The following is a description of a gene set: Reactome Pathway: Aflatoxin activation and detoxification electronically inferred by orthology from the curated human pathway species: Mus musculus part of: Biological oxidations This event has been computationally inferred from an event that has been demonstrated in another species.<p>The inference is based on the homology mapping from PANTHER. Briefly, reactions for which all involved PhysicalEntities (in input, output and catalyst) have a mapped orthologue/paralogue (for complexes at least 75% of components must have a mapping) are inferred to the other species., and this is the list of marker genes: Cyp3a16, Cyp3a25, Acy3, Cyp3a57, Ggt7, Cyp2a12, Cyp3a13, Ggt5, Ggt6, Cyp3a11, Cyp3a41a, Dpep2, Ggt1, Cyp1a2, Cyp2a4, Cyp3a44, Dpep1, Mgst2, Cyp3a41b